The following is a description of a gene set: studied in species Mus musculus Mouse Gene Set: GOBP_DIGESTIVE_SYSTEM_DEVELOPMENT The process whose specific outcome is the progression of the digestive system over time, from its formation to the mature structure. The digestive system is the entire structure in which digestion takes place. Digestion is all of the physical, chemical, and biochemical processes carried out by multicellular organisms to break down ingested nutrients into components that may be easily absorbed and directed into metabolism., and this is the list of marker genes: Hip1r, Hmgcs2, Wnt5a, Tcf7l2, Acvr2b, Ctnnb1, Pdgfra, Cobl, Tcf21 (transcription factor 21), Sfrp2, Igf2 (NCBI Gene Id 16002), Fgfr2, Otc, Wdpcp, Id2, Tgfb2 (transforming growth factor, beta 2), Gsdmc2, Mir7-1 (NCBI Gene Id 723902), Pdgfa, Hoxd13, Cfc1, Reg1, Dchs1, Igf1r, Ephb3, Ugt1a1, Cdkn1a, Spdef, Rb1, Chrd, Ptf1a, Bcl2, Pcsk5, Gli2, Pkdcc, Muc19, Epb41l5, Sox11 (SRY (sex determining region Y)-box 11), Gata6, Cyp1a1, Ovol2, Rbpms2, Wnt11, Klf5, Nkx3-2, Yap1, Fat4, Percc1, Prdm1, Pdx1, Cdx1 (caudal type homeobox 1), Shox2, Nipbl, Foxf1, C1galt1, Ass1, Fgf9, Mir203, Nkx2-2, Gata4, Pdgfc, Clmp, Mir7-2, Ihh, Smad2, Tnf, Nkx2-3 (NK2 homeobox 3), Pkd1, Hes1, Cbfa2t2, Cdkn1c, Fgfr3, Xbp1, Tmigd1, Nodal, Dact1, Hnf1b, Vps52 (VPS52 GARP complex subunit), Foxp4, Il6st, Ptk6, Ccdc103, Tigar, Mixl1, Col3a1, Nfe2l2, Filip1l (NCBI Gene Id 78749), Tgfb1 (transforming growth factor, beta 1), Rcbtb2, Cckbr, Smo, Kcnq1, Ext1, Rarb, Sox17, Hlx, Lgr4, Foxl1, Foxf2, Fgf10, Ccdc39, Myb, Tcf7, Cldn18, Wdr19, Egfr, Tlr9, Insr, Sav1, Rarres2, Srp54a, Ascl1, Hoxa5, Six2, Zic3, Vangl2, Sox9, Smad3, Foxe1, Sall1, Crkl, Stra6, Ccdc40, Notch1, Npr2, Dicer1, Agr2, Alx4, Gata5, Dnaaf1, Aldh1a2, Ednrb, Pitx2, Sfrp1, Chd8, Fzd5 (NCBI Gene Id 98335), Cdh1, Gip, Nkx2-6, Hif1a, Ada, Kit, Igf1, Cdx4, Gli3, Megf8, Tyms, Cdx2, Nr5a2, Sox10, Oxtr, Hrh2, Myocd, Trp63, Cps1, Shh, Nckap1, Yipf6, Src, Nphp3, Nkx6-3, Hoxa13, Cela1, Ift172, Sfrp5, Barx1, Trp73, Stx2, Wls